The following is a description of a gene set: The specific behavior of an organism that recur with measured regularity. species: Mus musculus Mouse Gene Set: GOBP_RHYTHMIC_BEHAVIOR, and this is the list of marker genes: Pten, Mup5 (NCBI Gene Id 17844), Adrb1, Six3, Kcnq1, Nlgn3, Csf2, Csnk1e, Gabrb3, Cntnap2, Mup1, Fxr1, Usp2, Cort, Ncoa2, Mapk10, Mtnr1b, Mup3, Ptgds, Th, Trp53, Mup11 (major urinary protein 11), Oprl1, Btbd9, Ghrl, Egr2, Adora1, Bloc1s6 (NCBI Gene Id 56387, biogenesis of lysosomal organelles complex-1, subunit 6, pallidin), Adora2a, Drd3, Mup2, 2510009E07Rik, Ahcy, Gpr157 (NCBI Gene Id 269604), Per3, Nr1d2, Nps, Uts2, Nms, Parp1, Nr1d1, Rogdi, Drd1, Ncor1, Egr1, Npy2r, Pln, Chat, Nmu, Pmch (NCBI Gene Id 77764), Ankfn1, Lepr, Ptger4, Kcna2, Drd2, Gpr176, Il6, Nlgn1 (NCBI Gene Id 99949), Zfhx3, Hcrtr2, Kcnd2, Mc3r, Chrnb2, Alb, Mup4, Ada, Mtor, Ghrhr, Kcnma1, Id2, Uts2r, Casp1, Ciart, Ahcyl, Npas2, Ghrh, Ptger3, Naglu, Mta1